Given this list of marker genes EPHB4, EPHA2, EFNB1, TIAM1, CDK5R1, EFNB2, RBPJ, NTRK3, EPHB2, RASA1, EFNA1, SS18, EPHA1, EFNA2, ANKS1A, ARHGEF28, PTK2, PAK3, EPHA4, NCK1, EPHA6 (NCBI Gene Id 647649), EFNB3, ARHGEF7, EPHA8, CRK, MMP9, EPHB1, EPHA5, CHN1, EFNA3, GIT1, EFNA4, EPHB6, NGEF, ABL1, NTRK1, LYN, ANKS1B, NCK2, MMP2, KALRN, EFNA5, SIPA1L1, EPHA7, PTPN11, FYN, SRC, EPHA10, EPHA3, YES1, EPHB3, PAK1, MIR519D, here is a description of the gene set: Human Gene Set: GOBP_EPHRIN_RECEPTOR_SIGNALING_PATHWAY The series of molecular signals initiated by ephrin binding to its receptor, and ending with the regulation of a downstream cellular process, e.g. transcription. species: Homo sapiens